The following is a description of a gene set: from publication Chessler AD, Unnikrishnan M, Bei AK, Daily JP, Burleigh BA (PMID 19201883) To investigate the early host response triggered by three different strains of Trypanosoma cruzi at a local infection site, changes in host gene expression were monitored in a murine intradermal infection model using Affymetrix oligonucleotide arrays. Robust induction of IFN-stimulated genes (ISGs) was observed in excised skin 24 hours post-infection where the level of ISG induction was parasite strain-dependent with the least virulent strain triggering a muted IFN response. Infection of mice immunodepleted of IFNγ-producing cells or infection of IFNγ-deficient mice had minimal impact on the IFN response generated in T. cruzi infected mice. In contrast, infection of mice lacking the type I IFN receptor demonstrated that type I IFNs are largely responsible for the IFN response generated at the site of infection. These data highlight type I IFNs as important components of the innate immune response to T. cruzi the site of inoculation and their role in shaping the early transcriptional response to this pathogen. We used microarrays to detail the local host transcriptional response to intradermal T. cruzi infection in WT mice and mice depleted of NK cells, or deficient in IFN-gamma or type I IFN responses. Additionally we compared the local host-transcriptional response generated to infection with 3 different strains of Trypanosoma cruzi (Y, Brazil, and G). Human Gene Set: GSE13522_CTRL_VS_T_CRUZI_Y_STRAIN_INF_SKIN_IFNAR_KO_DN Genes down-regulated in skin after injection of Trypanosoma cruzi (strain Y): wildtype (129S1) versus IFNAR1 knockout. studied in species Homo sapiens, and this is the list of marker genes: ZCCHC18, NFIL3, C6orf89, SDHAF1, MFSD4A, PLPP1, CXCR3, CLSTN1 (calsyntenin 1), SLC35D1, CYFIP1, TRIM14, LIX1L, SH3BGRL2, EPCAM, ACOT7, HIVEP3, TRPM1, LAD1, TIAM1, DUSP4, FRMD4B, PLCB3, CEP55, FSD2, HOPX, NCF4, MCM6, MXD1, MDFIC, ETV5, ANG, LRRC61, TGIF1, XBP1, TGM2, MAGED2, ALDOC, MCUB, PDCD1 (NCBI Gene Id 56179), TOR4A, ALAD, GALM, STAT5A, IL2RA, PDCD1LG2, NAF1, RNF216, SUSD2, RUNDC3A, TSPAN3, CNKSR3, SRC, CMTM7, GABARAPL1, ADAM19, DBNDD2, PAFAH1B3, SLC45A4, CD81, SYNPO, SP6, P2RX7, DHRS3, TRAM2, AKR1B10, DUSP5, LRRC8D, STING1, SMYD2, CUL7, KCNK6, REXO2, RECK, C1QTNF12, ACTG2, LZTS2, S100A4, PHLDA1, CD79B, FMNL3, RFX5, IL12RB1, PRELID2, IRAG2, IRF4, CST7, DAPP1, TMEM158, LAG3, TNFRSF18, CUEDC1, ENSG00000286190, CAPG, CD99L2, GADD45G, PEAR1, STX11, IZUMO1R, PRNP, ST3GAL2, CYB5A, AXL (NCBI Gene Id 558), EEF1AKMT1, ACOT11, PLEKHB2, CHSY1, PTPN9, CAPN3, XDH, ETFBKMT, NSMF, ERGIC1, DENND5A, IGF2R, ANXA4, ITIH5 (NCBI Gene Id 84903), EGR2, ARHGAP20, IL1R2, CD200, HSD3B7, GPX4, NFKBIA (NFKB inhibitor alpha), LITAF, PHLPP1, ABHD4, CASP7, SLC22A2, CMTM3 (NCBI Gene Id 123920), EPHX1, TMEM64 (transmembrane protein 64), TNIP1, RXRA, IRAK2, BID, UNC119, HNRNPLL, ENO3, PTGER2, ALKBH6, GPR83, GNA12, CDK6, LYSMD2, CTTN, MX2, GLRX, SLC7A10, BMP7, RALGDS, CERK, RNASE4, TSPAN31, SLC41A1, CXCR5, GFI1, CTLA4, C3orf80, GATA1, MTMR3, LPXN, TJP2, ZC3H12D, NCMAP, ACSBG1, NRP1, SHE, ELK3, ENDOD1, SDCBP2 (NCBI Gene Id 27111), RUNX2, GPR68, AHCYL2, OAZ2, PLGRKT, LTA4H, TMBIM1, YDJC, NOD1, BHLHE40, SPRY1, ICAM1 (intercellular adhesion molecule 1), C16orf74, PRG4, JDP2, TRIP13, COMT, PBX2, SUOX, CRMP1, GPR15, WLS, SLC25A53, NAGA, CD83, ANGPTL2, E2F3 (NCBI Gene Id 1871), UBE2L6, SH3GL3, FABP5